The following is a description of a gene set: studied in species Mus musculus Mouse Gene Set: GOMF_ATP_DEPENDENT_ACTIVITY_ACTING_ON_DNA Catalytic activity that acts to modify DNA, driven by ATP hydrolysis., and this is the list of marker genes: Chd7, Rfc2, Atrx, Twnk, G3bp1, Rbbp4, Chd4, Dmc1, Mcm7, Npm2, Recql4, Chd8 (NCBI Gene Id 67772), Mcm4, Rad17, Sub1 (SUB1 homolog, transcriptional regulator), Rad54l2, Smarcad1, Mre11a, Chtf8, Xrcc5, Dhx36, Upf1, Chd1, Pif1, Hfm1, Ascc3, Rad51b, Rfc5, Smarca4, Smarca1, D1Pas1, Bptf, Top2a, Chd2, Smarcal1, Cdk7, Mcm3, Ercc6, Ercc2, Brip1, Blm (NCBI Gene Id 12144), Rfc4, Rad51d, Dqx1, Chtf18, Msh5, Ercc3, Helq, Nav2, Wapl, Wrn, Mcm6, Msh2, Msh6, Gtf2f2, Rad54b, Xrcc3, Polq, Trp53, Mcm5, Ddx11, Ddx3x, Rad51c, Top2b, Chd5, Ighmbp2, Helb, Dhx30, Rtel1, Ruvbl2 (RuvB-like AAA ATPase 2), Rad54l, Arid1a, Smarca5, Hltf, Wrnip1, Zranb3, Fbh1, Mcm2, Msh3, Ddx1, Xrcc2, Rad50, Recql5, Chd3, Pms2 (NCBI Gene Id 18861), Msh4, Rfc3 (NCBI Gene Id 69263), Cecr2, Dna2, Top6bl, Smarca2, Mlh1, Chd9, Dhx9, Ruvbl1, Chd1l (NCBI Gene Id 68058), Ino80, Rfc1, Chd6, Mcm8, Atad5, Rad51, Ttf2, Xrcc6, Btaf1, Dscc1, Fancm, Mcm9, Spo11, Zgrf1, Anxa1, Supv3l1, Myd88, Ercc6l, Recql